The following is a description of a gene set: studied in species Mus musculus Mouse Gene Set: GOBP_REGULATION_OF_EXCITATORY_SYNAPSE_ASSEMBLY Any process that modulates the frequency, rate or extent of excitatory synapse assembly., and this is the list of marker genes: Prickle1, Cript (NCBI Gene Id 80506), Ptprd, Clstn3, Sipa1l1, Lats1, Ptk2b, Lrrc4b, Caskin1, Lrrtm2, Lrfn1, Cbln1 (NCBI Gene Id 12404), Nrxn1, Ptprs, Lrfn4, Il1rap, Sema4a, Lrrtm1, Ptpn13, Fgfr1, Nlgn1, Vstm5, Grid2, Wnt7a, Prickle2, Abi3bp, Abi3